Given this list of marker genes DSP, STK11, CAST, KANK2, PEX6, PLCD1 (NCBI Gene Id 5333), GJB2, ATP2A2, GJA1, TRPS1, KIF11, RNU4ATAC, ABCA12, PEX1, ATR, FOXC2, DSG1, KLK11, DSC3, here is a description of the gene set: Abnormality of nail color studied in species Homo sapiens Human Gene Set: HP_ABNORMALITY_OF_NAIL_COLOR An anomaly of the color of the nail.